The following is a description of a gene set: Any process that results in a change in state or activity of a cell or an organism (in terms of movement, secretion, enzyme production, gene expression, etc.) as a result of a type III interferon stimulus. Interferon lambda is the only member of the type III interferon found so far. Mouse Gene Set: GOBP_RESPONSE_TO_TYPE_III_INTERFERON studied in species Mus musculus, and this is the list of marker genes: Epg5, Ifngr2, Ifnlr1, Shfl, Ifng, Ifngr1